Given this list of marker genes CORO6, SNX12, GTF2A1, MRC2, WDFY3, BARHL2, DRP2, CD69, BTK, RAB10, ERO1A (endoplasmic reticulum oxidoreductase 1 alpha), PLBD2, VCP, SPTBN4, SATB1, VPS26A, KCNE4, ATP6V0A1, FGF9, TUBB, BEX2, GRK6, PCYT1A, ITM2B, CADM1, TFEC, PRRC2C, PSMA2, KCNA2, CA10, NRN1L, SNCB, RAB5IF, MIR22HG, REXO2, HSPB3, MGST1, OMG, LRRTM4, NECAB3 (NCBI Gene Id 63941), EIF4G1, FAM219A, LRP1B, POPDC3, WDFY3-AS2, RASGRF1, LOXL4, CBX6, PSMA5, MLLT11, SECISBP2L, JADE1, ENO1, KMT2C, PFN2, ATP1B1, DEPDC7, TIAL1, KIRREL3, PCDHA10, PLS3, ALDOA, WNT3, SOX5, TLK1, ONECUT2, NRXN2, LAMC1, TECPR1, FGF12, TNRC6A, SERPINB5, RBBP7, DENND2B, RABEP1 (NCBI Gene Id 9135), MDM2, IFNB1, PAFAH1B1, HECTD2, TEKT5, TBC1D17, HSD11B1, PRDX1, USP14, OSER1, SPRED1, NUDT11, BLVRB (biliverdin reductase B), GRIK2, PDHA2, LMTK2, SV2B, CST7, ARHGEF11, ANGPT1, FAM184A, SLC6A5, SLC6A4, PPARG, TBL1X, PPARGC1A, SEL1L3, P2RX6, JAZF1, ZIC4, ITPK1, DUSP13B, PGRMC1, PSMA6, CLC, PCDHA1 (protocadherin alpha 1), RORB, FBXO30, NUDT10, JOSD1, GPX2, DYNC1I1, SPTA1, ARPP19, PIANP, TOMM70, STON2, EIF5, TINAG, UFD1, IL6, WDR44, PCDH9, TXNRD1, TMCC1, UCHL1, NPEPPS, LEPROTL1, JARID2, UBR4, TAC1, E2F3, PPP2R2C, PCDHA6, AKT1S1, CD200R1, CDC45, LIN54, MITF, CBY2, LMO4, TEX19 (NCBI Gene Id 400629), SLC11A1, UBE4B, IPO13, FLI1, RBFOX1, RAB1A, DMD, ASB2, BIRC6, PADI4, MEIS2, LRRFIP2, FOXP1, IL13RA1, FLNC (filamin C), RTN3, TFAP2D, CALM3, PSMD11, NEUROD6, CRYGS, UNKL, NLGN2, WDR81, SOBP, PDGFB, PTCH1, OSBPL5, PPP2CA, MNT, PRR7, TUBA1C, FOSL1, SYT2, SFXN5, HSPB8, LIMK1, FIBCD1, PBX2, GAP43, PTP4A1, SPATS2, ATXN7L2, TLL1, SKP1, CDC42SE1, ASPSCR1, BRD2, NRGN, IRX4, ATP2A3, SHANK2, ABCB6, GAB2, MRPL32, GAST, DNAI1, RIMS2, NUMBL, here is a description of the gene set: species: Homo sapiens Genes having at least one occurrence of the motif NNNNNATGACTCAGCANTTNNG in the regions spanning 4 kb centered on their transcription starting sites. This matches the TCF11, MAFG transcription factor binding site V$TCF11MAFG_01 (v7.4 TRANSFAC). Human Gene Set: TCF11MAFG_01